Given this list of marker genes DGAT1, ACSL3, BIN1, SNX9, ZDHHC8, APOC3, SOAT1, APOM, PLAGL2, PRKACA, ABCA1, PRKACB, MTTP, LPCAT3, APOA4 (NCBI Gene Id 337), APOB, APOE, APOA1, PCDHGA3, MFSD2A, MIR144 (NCBI Gene Id 406936), FECH, ABCA7, APOC1, LCAT, APOA2 (apolipoprotein A2), PRKACG, CIDEB, SOAT2, NR1H2, here is a description of the gene set: Human Gene Set: GOBP_PROTEIN_LIPID_COMPLEX_ASSEMBLY species: Homo sapiens The aggregation, arrangement and bonding together of proteins and lipids to form a protein-lipid complex.